The following is a description of a gene set: species: Homo sapiens Combining with a bioactive lipid and transmitting the signal across the membrane by activating an associated G-protein; promotes the exchange of GDP for GTP on the alpha subunit of a heterotrimeric G-protein complex. A bioactive lipid is a lipid for which changes in lipid levels result in functional consequences in a variety of cellular processes. Human Gene Set: GOMF_BIOACTIVE_LIPID_RECEPTOR_ACTIVITY, and this is the list of marker genes: S1PR5, FFAR1, LPAR4, S1PR3, SPHK1, S1PR1, LPAR3, LPAR2, LPAR6, GPR174, SPHK2, S1PR4, GPR3, LPAR1, S1PR2 (NCBI Gene Id 9294), GPR31 (NCBI Gene Id 2853), GPR6